Given this list of marker genes NELFA, USB1, WRAP53, LETM1, LAMB3, NPM1, GALNT3, AXIN2, RAI1, PEX6, OCRL, FLII (NCBI Gene Id 2314), IFT122, PARN, NHP2, NOP10, NSD2, DKC1, MSX1, IFT43, NEK1, TGFA, BRF1, GREM2, EDARADD, ENAM, CHD3, PEX1, DLX3, WNT10B, WDR35, WDR19, RTEL1, IRF6, CTC1, TONSL, GJA1, LRP6, TERT, CDH11, EDA, FGF3, PIGG, CPLX1, DEAF1, TP63, TERC, WNT10A, IQSEC2, TYMS, SMOC2, BCOR, TINF2, IFIH1, SUMO1, CTBP1, IFT52, FGFR1, PAX9, here is a description of the gene set: An abnormality of the dental root. Human Gene Set: HP_ABNORMAL_DENTAL_ROOT_MORPHOLOGY studied in species Homo sapiens Abnormal dental root morphology